The following is a description of a gene set: studied in species Homo sapiens Breast cancer expression clusters. Human Gene Set: MODULE_480, and this is the list of marker genes: TRIP4, BET1L (NCBI Gene Id 93155), WNT3A, PMS2P1, DHRS3, COL4A5, FUZ, SLC5A1, MIS18A (MIS18 kinetochore protein A), PTHLH, SRPRB, GEMIN7, LHX3, GAS2, NUMA1, DNAJB1 (DnaJ heat shock protein family (Hsp40) member B1), GTPBP3, SIL1, SNED1, HLA-DRB4, AK3, YPEL3, SNX2, RAB3GAP2, YTHDF2, MAP4K2, LIMK2, GPD1, HSPA1B, GALC (NCBI Gene Id 2581), UQCC2, ZNF587, SYNGR1, SYT1, KIF13A, RNF139, HLA-DPA1, KCND1, PSEN1, BOD1L1, NDUFAF3, AP1S1, SINHCAF, TIMP1, CHCHD6, BMP6 (NCBI Gene Id 7964), ACSL3, FLVCR1, DMD, LEP, HS6ST1, ZNF224, NUP210 (NCBI Gene Id 79985), PILRB, SERPINA3, TRPM1, MIF4GD, FRMD4A, PLPP3, LBP, DCAF10, ZEB1, ZNF559, CRBN, CYRIA, PCTP, CISH, DLX5, ENOX1, NBPF3, CFI, SZRD1, IFI35, FGF13 (fibroblast growth factor 13), AZGP1, CCNB1 (NCBI Gene Id 891), NOL7, DNAAF8, THEMIS2, HMGN2, ATE1, FOSL2, CYTH1, FERMT2, MCTS1, TMEM143, MIEN1, SPOCK2, ALDH1B1, PYROXD1, OSBPL2, ABCA7, CARD16 (NCBI Gene Id 114769), AAGAB, RMDN3, PPP1R11, MAD2L2, CLSTN3